Given this list of marker genes AGPAT4, LPCAT1, ABHD4, ABHD8, CRLS1, ABHD5, MBOAT1, LPCAT3 (lysophosphatidylcholine acyltransferase 3), AGPAT2, MBOAT7, GPAT2, GPAT3, LPCAT4, LPGAT1, TAFAZZIN, MBOAT2, AGPAT3, LCLAT1, LPCAT2, PNPLA3, AGPAT5, AGPAT1, SH3GLB1 (NCBI Gene Id 51100), GPAT4, here is a description of the gene set: Human Gene Set: GOMF_LYSOPHOSPHOLIPID_ACYLTRANSFERASE_ACTIVITY Catalysis of the transfer of acyl groups from an acyl-CoA to a lysophospholipid. studied in species Homo sapiens